Given this list of marker genes IL37, IL18BP, IL4, IL18RAP, ALOX5, IL18R1, IL18, IL13, here is a description of the gene set: Human Gene Set: REACTOME_INTERLEUKIN_18_SIGNALING Interleukin-18 signaling species: Homo sapiens